The following is a description of a gene set: species: Homo sapiens Any process that stops, prevents, or reduces the frequency, rate or extent of nuclear division, the partitioning of the nucleus and its genetic information. Human Gene Set: GOBP_NEGATIVE_REGULATION_OF_NUCLEAR_DIVISION, and this is the list of marker genes: AURKAIP1, SKA1, AURKB, PSMG2, BUB1, PLK1, CENPF, DUSP1, RAD1, KNL1, XRCC3, BIRC5, SPDL1, DYNC1LI1, LIF, MAD2L2, CDCA8, SKA3, BMP7, LCMT1, CCNB1, CDK5RAP2, TEX14, NME6, PRAP1, NANOS2, GEN1, SPC25, ZWINT, TRIP13, PRP4K, BUB1B, BMP4, RAD21, ATM, TTK, MAD2L1, NDC80, APC, KLHL22, TPR, ZW10, USP44, NUF2, ANAPC15, BUB3, HASPIN, FBXO43, CHEK1, ZNF207 (NCBI Gene Id 7756), SPC24, MAD2L1BP, MAD1L1, HORMAD1, INCENP, FBXO5, KNTC1, TOM1L1, RPS6KA2, CDC20, IK, ZWILCH, DMRT1, TOM1L2, MTBP